The following is a description of a gene set: Cargo trafficking to the periciliary membrane species: Mus musculus Mouse Gene Set: REACTOME_CARGO_TRAFFICKING_TO_THE_PERICILIARY_MEMBRANE, and this is the list of marker genes: Exoc2, Pkd2, Arl3 (ADP-ribosylation factor-like 3), Exoc7, Rab11a, Lztfl1, Inpp5e, Arl6, Exoc8, Sstr3, Rho, Pkd1, Cnga4, Smo, Bbs2, Exoc1, Bbs7, Exoc5, Asap1, Arf4, Bbs1, Pde6d (NCBI Gene Id 98438), Exoc4, Exoc3, Rab3ip, Arl13b, Bbs5, Ttc8, Nphp3, Cngb1, Mchr1, Bbs9, Gbf1, Unc119b, Rab11fip3, Rab8a, Rp2, Cnga2, Bbs4